The following is a description of a gene set: Human Gene Set: GOBP_NEGATIVE_REGULATION_OF_NOREPINEPHRINE_SECRETION Any process that decreases the frequency, rate or extent of the regulated release of norepinephrine. studied in species Homo sapiens, and this is the list of marker genes: ADRA2A, P2RY1, ADRA2C, CRH, ADRA2B, GHSR